Given this list of marker genes IKBIP, NWD1, MAP2K6, CGRRF1, DDT, ZNF627, MASTL, GLA (galactosidase alpha), ZC3H12D, DUSP19, ME2, OXR1, CYLD, GBE1, SHCBP1, GINS4, MRPL9 (mitochondrial ribosomal protein L9), SLC37A4, RAB9A, UBE2T, THOC7, KNSTRN, HLA-A, GLO1, DHX40, LYPD6B, MTMR14, GRHPR, AKR1B10, SELENBP1, MLLT3, FBXO33, SNX1, ALKBH4, DNAJB4, MXI1, BCL2L11, EZH1, KIF22, IPCEF1, MFSD11 (major facilitator superfamily domain containing 11), ARHGEF18, CCNG2, TTC33, ZNF436, KIF18A, ADCY7, PAPSS1, WDR45, TMT1A, TTC9C, NR2C2, HIKESHI, RAP2A, YPEL5, ADD3, YPEL2, TFDP2, HMMR, GATD1, TMEM107, CCDC28A, CYRIA, KIF21B, PDE3B, ZNF260, TCF19, CDIN1, RNF103, CENPL, SH3YL1, MGARP, NME7, ARRB1, SPICE1, EID1, ZNF708, IL16, PTPN22, PLPP2, STX5, NGLY1, FBXL20, TMEM71, RRAS, LRR1, NEK1, OTUD1, UROD, TTLL1, PEX6, RPAP2, TESK2, PNKD, WRAP73, FAM53C, MXD3, UEVLD, RNF181, LETMD1 (NCBI Gene Id 25875), SORD, GLOD4, IFT27, PRUNE1 (NCBI Gene Id 91961), ATG9A, SKA1, HSPA2, UBE2H, RMND5A, RDH12, FBXO32, KIF2C, INVS, SDC4, SLC43A2, VIPAS39, ZNF394, CYP2S1, NDRG1, SLC39A4, KDELR1, TRIM45, MTURN, RGS2, PEX13, FOXO3, D2HGDH, CHST12, JMY, CCNF, PAFAH1B3, OXLD1, CNEP1R1, ACBD5 (NCBI Gene Id 91452), GOLPH3L (golgi phosphoprotein 3 like), KIF3C, MTERF2, ETFDH, SNX20, BEND5, GPANK1, FBXO25, TMEM38A, GMNN, CROT, RNASEH2A, IMPA2, TNFAIP8L1, DAG1, PPP1R3G, NSMCE4A, MAF1, MAP1LC3B, ELF1, SMAD7, PAICS, BSDC1, CDCA5 (NCBI Gene Id 256676), PYGL, FAM114A1 (NCBI Gene Id 92689), INTS10, TMEM106C, RBBP9, TENT5C, CDKN2C, TRIM59, PAIP2, KLHL32, RIPOR1, TOB1, TNIP1, PARP16, TWF2, KCNN4, RILPL2, NBR1, RBM14, KIF20A, CEP128, BCL6, MTIF3, PKP2, RASGEF1A, SELENOP, ZSWIM3, HSDL1, NADK2, APBB1, S1PR4, GIT2, OSER1, AURKA, CRYZ, CCPG1, DAPK2, DNAAF5, KIF18B, STK38, ZNF395, RBM10, here is a description of the gene set: from publication Busconi L, Bauer JW, Tumang JR, Laws A, Perkins-Mesires K, Tabor AS, Lau C, Corley RB, Rothstein TL, Lund FE, Behrens TW, Marshak-Rothstein A (PMID 18025183) Genes up-regulated in B lymphocytes: control versus anti IgM and CpG oligodeoxynucleotide 1826. species: Homo sapiens We have previously shown that rheumatoid factors (RF) produced by Fas-deficient autoimmune-prone mice typically bind autologous IgG2a with remarkably low affinity. Nevertheless, B cells representative of this RF population proliferate vigorously in response IgG2a/chromatin immune complexes through a mechanism dependent on the sequential engagement of the BCR and Toll-like receptor 9 (TLR9). To more precisely address the role of both receptors in this response, we analyzed the signaling pathways activated in AM14 B cells stimulated with these complexes. We found that the BCR not only serves to direct the chromatin complex to an internal compartment where it can engage TLR9 but also transmits a suboptimal signal that in combination with the signals emanating from TLR9 leads to NF-kappa-B activation and proliferation. Importantly, engagement of both receptors leads to the upregulation of a group of gene products, not induced by the BCR or TLR9 alone, that include IL-2. These data indicate that autoreactive B cells, stimulated by a combination of BCR and TLR9 ligands, acquire functional properties that may contribute to the activation of additional cells involved in the autoimmune disease process. Human Gene Set: GSE6674_UNSTIM_VS_ANTI_IGM_AND_CPG_STIM_BCELL_UP